Given this list of marker genes Gsk3a, Esr1, Fgf15, Prkci, Rnasel (NCBI Gene Id 353203), Fabp5, Slc25a27, Sorbs1, Ace, Mfn2, Ak1, Appl2, Ocln, Ednra, Mapk14, Klf15, Rtn2, Aspscr1, C1qtnf2, Irs2, Repin1, Mef2a, Sh2b2, Oga, Opn3, Appl1, Prkca (NCBI Gene Id 18750), Grk2, Ffar4, Gh, Clip3, Nr4a3, Akt2, Pid1, Adipoq, Slc1a2, Pth, Enpp1, Inpp5k, Ptpn11 (NCBI Gene Id 72646), Edn1, Stxbp4, Osbpl8, Akt1, Lep, Crebl2, Prkcb, Igf1, Prkcd (protein kinase C, delta), Tert, Aoc3, Smim43, Ins1, Ins2, Sirt6, Gip, Rps6kb1, Upk3b, Tnf, C2cd5, Pou4f2, Met, C3, Yes1, Capn10, Hk2, Ahi1, C1qtnf12, Stxbp3, Pea15a, Erfe, Insr, Nfe2l2, Cers1, Rap1a, Irs1, Grb10, Erbb3, Myc, Rhoq (NCBI Gene Id 80836), Ostn, Il1b, Rasa1, Fgf21, Itln1, Adipor2, Erbb4, Trib3, Gpc3, Braf, here is a description of the gene set: studied in species Mus musculus Any process that modulates the frequency, rate or extent of glucose transport across a membrane. Glucose transport is the directed movement of the hexose monosaccharide glucose into, out of or within a cell, or between cells, by means of some agent such as a transporter or pore. Mouse Gene Set: GOBP_REGULATION_OF_D_GLUCOSE_TRANSMEMBRANE_TRANSPORT